Given this list of marker genes Pa2g4, Flt4, Abhd17b, Armc1, Slc2a9, Lss, Ppargc1a, Btg1, Ifi211 (interferon activated gene 211), Dock10, Plekha8, Hspa4, Map4, Dcaf6, Marchf5, Crebl2, Ptpn3, Nsun4, Alkbh5, Cyp2g1, Fip1l1, Deup1, Daam1, Ankrd44, Hoxb8, Rbfox1, Tmem33, Rngtt, Tnfrsf26 (NCBI Gene Id 244237), D5Ertd579e, Gp2, Cenpw, Pdyn (prodynorphin), Nlgn1, Psme4, Fgf14, Rab18, Csf1, C3ar1, Tmem59, Camk2b, Zbtb44 (NCBI Gene Id 77873), Pcdh9, Rasal2, Rc3h1, Sox5, Dync2li1, Btbd3, Cflar, Gramd2b, Lrrn1, Nsrp1, Chic1, Dpp10, Fam177a2, Tspan12, Hid1 (NCBI Gene Id 217310), Otop1, Acbd3, Zmym2, Trim33, Rreb1, Ecm2, Fam177a, Magi3, Nf1, Adnp, Etnk1, Dlx1, Rora, Kctd12, Stk31, Lrrcc1, Sorcs1, Kti12, Rorb, Chodl, Cttnbp2nl, Huwe1, Mkks, Npr3, Sim1, Top1, Chtf8, Agpat5, Pias2, Rab5c, Psmb11, Tspan3, Zfx, Ralgapa2, Bmp5, Fnip1, Slc25a24, Irf6, Susd1, Mal2, Slc35a2, Ykt6, Ubr5, Ifi205, Slc22a23, Zfp622, Appl1, Lrrc7, Zranb3, Rpf1, Itpripl2, Blcap, Bdnf, Cnst, Kmt2a, Cdc7, Smad4, Lrrc47, Fignl2, Mlycd, Kcns3, Etaa1, Arpc5, Ro60, Septin7, Sdc2, Enpp2, Ankle2, Golm2, Gabra5, Cers6, Rragb, LTO1, Eif2b2, Prickle2, Ikzf2, Hgd, Pla2g4d, Specc1, Iqgap2, Emp2, Smad7, Tpd52l1, Kmt2e, Snrk, 1700025G04Rik, Asxl2, Rsrc2, Sall2, Chst2, St3gal2, Rad21, Ncoa5, Arc, Scarf1, Sephs1, Ehmt1, Kdm7a, Ado, Dsp, Vcl, Nufip2, Camk4, Clasp2, Aadacl3, Crkl, Tpbg, Akap11, Frem1, Gabpb2, Otulin, Mboat1, Srp54a (NCBI Gene Id 24067), Magi1, Spred1, Zfp704, Arhgap29, Polr3a, Zcchc3, Sox17, Met, Ttc38, Acot11, Hoxd10, Kmt5b, Ugcg, Cnot6l, Rcor1, Shisa9, Erbb2, A930018P22Rik (NCBI Gene Id 68243), Rbm38, Lnx2, Nfat5, Snx2, Rilpl1, Prdm6, Aldh1a3, Iqsec1, Nrg3, Gramd1c, Vps26c, Thap1, Irf2bpl, Pcdhb3 (NCBI Gene Id 93874), Adamtsl1, Pde6a, Npat, Kif18b, Arid5b, Pknox1 (Pbx/knotted 1 homeobox), Spin1, Tmtc1, Gnai1, Ptprj, Unk, Pgap1, Zfp395, Neurl1b, Fsd1l, Mndal, Gpatch2l, Baalc, Fam187b, here is a description of the gene set: Mouse Gene Set: MIR_7243_3P from publication Chen Y, Wang X (PMID 31504780) Genes predicted to be targets of miRBase v22 microRNA mmu_miR_7243_3p in miRDB v6.0 with MirTarget v4 prediction scores > 80 (high confidence targets). studied in species Mus musculus